The following is a description of a gene set: Mouse Gene Set: GOBP_POSITIVE_REGULATION_OF_NITRIC_OXIDE_SYNTHASE_ACTIVITY species: Mus musculus Any process that activates or increases the activity of the enzyme nitric-oxide synthase., and this is the list of marker genes: Fcer2a, Esr1, Akt1 (NCBI Gene Id 268604), S100a1, Gch1, Tert, Dhfr, Htr2b, Nus1, Scarb1, Terf2